Given this list of marker genes CNTFR, DACH1 (dachshund family transcription factor 1), UBR3, POU4F1, UBE2Q1, PEX13, DERL2, HAND2, HELT, GLS, here is a description of the gene set: Specific behavior of a newborn or infant mammal that results in the derivation of nourishment from the breast. Human Gene Set: GOBP_SUCKLING_BEHAVIOR studied in species Homo sapiens